Given this list of marker genes ERCC6, ANKRD55, ERCC8, CD247, CCBE1, FAT4, THRB, STAT4, IL2RB, IGFALS, PRKAR1A, ADAMTS3 (ADAM metallopeptidase with thrombospondin type 1 motif 3), PTPN2, PTPN22, CDAN1, PTRH2, IL2RA, here is a description of the gene set: Mild postnatal growth retardation studied in species Homo sapiens Human Gene Set: HP_MILD_POSTNATAL_GROWTH_RETARDATION A mild degree of slow or limited growth after birth, being between two and three standard deviations below age- and sex-related norms.